The following is a description of a gene set: Genes down-regulated in Wilm's tumor samples compared to fetal kidney. Wilms' tumor (WT) has been considered a prototype for arrested cellular differentiation in cancer, but previous studies have relied on selected markers. We have now performed an unbiased survey of gene expression in WTs using oligonucleotide microarrays. Statistical criteria identified genes as differentially expressed between WTs and fetal kidneys. This set contained 124 matches to genes on a microarray used by Stuart and colleagues (Stuart RO, Bush KT, Nigam SK: Changes in global gene expression patterns during development and maturation of the rat kidney. Proc Natl Acad Sci USA 2001, 98:5649-5654) to establish genes with stage-specific expression in the developing rat kidney. Mapping between the two data sets showed that WTs systematically overexpressed genes corresponding to the earliest stage of metanephric development, and underexpressed genes corresponding to later stages. Automated clustering identified a smaller group of genes that were highly expressed in WTs compared to fetal kidney and heterologous tumor and normal tissues. This signature set was enriched in genes encoding transcription factors. Four of these, PAX2, EYA1, HBF2, and HOXA11, are essential for cell survival and proliferation in early metanephric development, whereas others, including SIX1, MOX1, and SALL2, are predicted to act at this stage. SIX1 and SALL2 proteins were expressed in the condensing mesenchyme in normal human fetal kidneys, but were absent (SIX1) or reduced (SALL2) in cells at other developmental stages. These data imply that the blastema in WTs has progressed to the committed stage in the mesenchymal-epithelial transition, where it is partially arrested in differentiation. The WT-signature set also contained the Wnt receptor FZD7, the tumor antigen PRAME, the imprinted gene NNAT and the metastasis-associated transcription factor E1AF. Human Gene Set: LI_WILMS_TUMOR_VS_FETAL_KIDNEY_1_DN studied in species Homo sapiens from publication Li CM, Guo M, Borczuk A, Powell CA, Wei M, Thaker HM, Friedman R, Klein U, Tycko B (PMID 12057921), and this is the list of marker genes: ESYT1, APOBEC3B, MAP4K4, ST6GAL1, MPHOSPH9, PRRC2B, YWHAZ, CDH2, NELL2, DLG5, TARBP2, SNRPA1, BUB3, SHMT2, H2AZ1, MLXIP, ABCA2, HMGA2, STMN1, MSH2, WASF3, ADIPOR2, ROR2, GCN1, ELOVL2 (NCBI Gene Id 54898), CKS2, PBX3, SIX1, ESPL1, TOPBP1, ACP1, CHN1, CENPF, PTTG1, COL2A1, FAM216A, MYL6B, DDX23, PRIM2, BCL7A, UCK2, CDKN3, SS18, YAF2, CKAP5, RNASEH2A, TCERG1, CHAF1A, PRIM1, SCRN1, FANCI, EZH2, NAP1L1, GARS1, DNAJC9, TP53BP2, UNG, RFC5, NASP, ADD2, PCNA, TAF5, CKS1B, SNRPF, ZNF423, STRAP, CHST1, TXNRD1, AURKA, MN1, PCLAF, TMSB15A, SALL2, CDK2, PLK4, BOP1, SPAG5, CBX5, MKI67, BUB1B, NUP205, FADS2, IARS1, MELK, SMC4, KIFC1, MSH6, ASNS, FEN1, CRABP2, KPNA2 (NCBI Gene Id 728860), NCBP2 (nuclear cap binding protein subunit 2), BLM, TOP2A, CIT, XPOT, BTAF1, PARP1, ZNF516, LMNB1, CDC25C, ILF2, TIA1, RRM1, DLGAP5, DDX52 (DExD-box helicase 52), FADS1, SLC16A1, PRPF40A, CCNB2 (NCBI Gene Id 9133), CDC20, TPX2, BAZ1A, NME1, GTF3C2, PPP2R2A, PFKP, DDX1, GREB1, MTHFD2, PCBP2, RSRC2 (arginine and serine rich coiled-coil 2), COL13A1 (collagen type XIII alpha 1 chain), CXCR4, HOXA9, MAD2L1, MCM2, SV2A, NR2C1, BRCA1, YARS1, MARS1, EYA1, KIF2C, FZD7, MCM6, TTK, TRIP13, XRCC5, KIF11, SACS (sacsin molecular chaperone), GPC1, HINFP, BAZ1B, ANKLE2, SRPK1, LIG3, TIMELESS, DKC1, SEPTIN6, CCND2, CACNB3, KIF23, NUP188, NOLC1, SSRP1, CADM1, CDK1, CCT3, LRP4, MEOX1, KIF14, AURKB, POLE3